The following is a description of a gene set: Human Gene Set: HP_ABNORMALITY_OF_EXTRAPYRAMIDAL_MOTOR_FUNCTION studied in species Homo sapiens Abnormality of extrapyramidal motor function A neurological condition related to lesions of the basal ganglia leading to typical abnormalities including akinesia (inability to initiate changes in activity and perform volitional movements rapidly and easily), muscular rigidity (continuous contraction of muscles with constant resistance to passive movement), chorea (widespread arrhythmic movements of a forcible, rapid, jerky, and restless nature), athetosis (inability to sustain the muscles of the fingers, toes, or other group of muscles in a fixed position), and akathisia (inability to remain motionless)., and this is the list of marker genes: PRRT2, EIF2AK1, GTF2I, VPS37D, ADAR, TACO1, SLC6A3, TBL2, SPG11, BUD23, ADGRV1, TPM2, PRKN (NCBI Gene Id 8004), TH, CYP27A1, PANK2, DCAF17, NR4A2 (NCBI Gene Id 4929), POLG2, TBP, GABRA1 (NCBI Gene Id 2554), SOD1, ATXN3, ATXN10, FUS, SORL1, POT1, CHCHD2, ZNF592, SCN1B, ATP7B, CHMP2B, APP, TBX1, SERPINI1, C19orf12, ALG13, PRNP, HLA-DQB1, LYST, RBM10, ACAT1 (NCBI Gene Id 38), TERF2IP, ATN1, HIKESHI, ATXN1, MT-TT, HCN1, SLC2A3, SYT1, CLIP2, HTRA1, PSEN1, ATCAY, TMEM106B, SERAC1, MITF, TMEM270, TBC1D24, TSPYL1, ATXN7, ARVCF, TSEN54, GRIA4, EARS2, ATXN2, NCF1, PDGFRB, XPC, FMR1, KLC2, MICU1, ELN, GAMT, GPHN, GLRB, HPRT1, ETHE1, SNCA, UFD1, SLC16A2, DNAJC6, NAGA, JAM2, MYPN, PDE8B, CTSF, ATP1A3, ATXN8OS, SCARB2, GTF2IRD1, DHDDS, FA2H, VPS13C, TARDBP, CDKN2B, TTC19, DENND5A, CP, ASNS, TNR (NCBI Gene Id 7143), PTPA, ERCC2, BRAT1, PCDH19, ABCA7, COQ2, CBS, LIPT1 (lipoyltransferase 1), GCH1, FTL, MED11, MC1R, ATP13A2, SYNJ1 (NCBI Gene Id 8867), WDR45, ZMYM2, GP1BB, SEC24C, OPA3, ENSG00000288330, HIRA, NOS3, NEB, PIGA, MINPP1, EIF2AK2, SCN9A, FKBP6, CHCHD10, MTHFS, ADH1C, PTS, CACNA1I, PLAA (phospholipase A2 activating protein), AP5Z1, COMT, SLC18A2 (solute carrier family 18 member A2), SLC2A1, NFU1, ERCC5 (NCBI Gene Id 2073), IFIH1, GLRA1, SNCAIP, RRM2B, FGF13, TOMM40, MPV17, PODXL, SPG21, TBK1, SAMHD1, ATP2B3, CLPB (NCBI Gene Id 81570), GABRD, JMJD1C, SLC6A5, DDC, PSEN2, ATP5MK, STX1A, DNAJC12, TERT, WDR73, RNASEH2A, KCNN2, FKTN, TK2, XPR1, RARS1, BOLA3, TREM2, COASY, POLG, MMACHC, NDUFS7, ZFYVE26 (zinc finger FYVE-type containing 26), ERCC4, ACD, C9orf72 (NCBI Gene Id 73205), AOPEP, GLB1, SYNE1, KCNC3, CAT, VPS35, TEFM (transcription elongation factor, mitochondrial), METTL27, DNAJC13, RNASEH2B, MPO, PURA, PRDX3, PRDX1, SLC6A9, TWNK, PRKRA, UQCRQ, PDE10A, ACTA1, CAMK2B, SLC25A4, TAF1, FBXO7, ITPR1, MECP2, XPA, NAA60, PTRHD1, LSM11, TSEN2, TANGO2, PSAP, LRRK2, DNAJC30, SPR, TMEM240, EIF4H, GM2A, UBAP1, GCSH, UQCRC1, UBTF, SLC30A10, PDGFB, FTH1, DPYS, AHDC1, LIMK1 (NCBI Gene Id 3984), RREB1, STX1B, PCBD1, KIF5A, GABRG2, ALS2, MYORG (NCBI Gene Id 57462), AFG3L2, APOE, SNORD118, CDK4, SNCB, RNU7-1, MAPT, PLP1, PPP2R2B (NCBI Gene Id 56686), CTC1, PARK7, PET117, JPH3, HEXB, CLN6, CDKN2A (cyclin dependent kinase inhibitor 2A), CLTC, SLC20A2, ERCC3, FLRT1, TPM3, GBA1, MGMT, RNASEH2C, BAP1, VPS13A, BAZ1B, SAMD9L, GIGYF2, TSPOAP1, DDB2, ATL1, SQSTM1, PIDD1, GTF2IRD2, L2HGDH, SLC39A14 (solute carrier family 39 member 14), TENM4, HEXA, CSF1R, TRPM7, HTT, PINK1, RAB39B, STUB1, GRN, UCHL1, ACBD6, TRAK1, KBTBD13, WARS2, DCTN1, NOTCH3, VCP, DNAJC5, EIF4G1, SCN1A, TREX1, HTRA2, RFC2, IMPDH2, ARHGEF9, TNIK (TRAF2 and NCK interacting kinase), SIGMAR1, PLAU (NCBI Gene Id 95176), SPTLC1, ATP6AP2, FARS2, PLA2G6, CLN3, PRKAR1B, SCN2A, GBE1, KLHL41